Given this list of marker genes SNORA16A, ANKRD55, ARL8B, LASP1, IL7R, SLC40A1, CD28, APLP2, CNOT6L, H2AC25, SUN2, LGALS3, STXBP5, KLHL21, CYB561D1, MYCBP2, AMDHD2, OGT, ATP2B1, SLC6A8, SAMD9L, TFRC, SLC23A2, PDLIM4, GPR162, KCNJ2, ABCA9, TRIB3, ALOX15, ATF3, CD300A, GSDME, LGALS3BP, KEAP1, PTPRO, HK3, PTK2B, GPR137B, SPAG9, TRAFD1, RNF128, SEMA4D, VWF, TSC22D1, AKIP1, IRGM, IGF2R, IFI44, PNPLA2, MYOF, ENTPD1, MICAL1, GABARAPL1, RPS4X, CXCL10, PTCHD1, GUSB, IRF7, GCLC, FABP4, LPL, SAMD8, AGAP1, STARD3, CHCHD6, DOT1L, WDR91, ADGRE5, UNKL, ZNFX1, OSBPL8, LMNA, PARP12, CPEB4, FLVCR1, IQGAP1, MBNL2, MYO1F, ATP10A, STRA6LP, PLXNC1, RELL1, MTHFR, TREX1, AHNAK, NCK2, PACS2, NFASC, PPT2 (NCBI Gene Id 9374), P2RY14, PTMS, CIPC, GVINP1, AHNAK2, SOAT1, PLD3, CACNA1A, BRI3, MX2, STAT2, MOV10, PDP1, MAP4K3 (mitogen-activated protein kinase kinase kinase kinase 3), IGF1, TRIM25, TALDO1, RGS1, RNF213, SYNE1, THEMIS2, TAPBP, KCNJ10, ANKRD12, CDS2, TTYH2, NIBAN2 (niban apoptosis regulator 2), STMP1, PLEKHM1, JAML, IFIT3, TPCN2, ZFYVE28, ZBP1, ATP6V1B2, STOM, ZYX, COX4I1, HERC5, ST8SIA4, PDXK, CLIC4, S100A6, DNASE1L1, DDX60, EEPD1, DOCK10, OASL, CDK6, OAS3, POR, GRK3, MNT, PLXNA1, PALS2 (NCBI Gene Id 55569), NR1D2, MX1, RRAGC, ATP6V0D2, RAB7B, PCYT1A, CLEC1B, CLEC7A, SLFN5, CD9, L1CAM, SLC49A4 (NCBI Gene Id 84925), ZFAND2A, LUC7L3, DNMT3A, LRATD2, CALM2, TMEM245, IFIT2, ASPH, GNS, GAS2L3, ANXA4, PSMB8, FNIP1, GPR183, IL6ST, ACSS2, ITPRID2, PARP11, PSEN2, XAF1, C6orf62, here is a description of the gene set: Human Gene Set: GSE21360_NAIVE_VS_SECONDARY_MEMORY_CD8_TCELL_DN The transcriptome of naive OT-I T cells was compared to memory CD8 T cells after 1, 2, 3, or 4 infection with ovalbumin expressing Listeria monocytogenes (LM-OVA). studied in species Homo sapiens Genes down-regulated in CD8 T cells: naïve versus 2' memory. from publication Wirth TC, Xue HH, Rai D, Sabel JT, Bair T, Harty JT, Badovinac VP (PMID 20619696)